The following is a description of a gene set: Mouse Gene Set: GOBP_MORPHOGENESIS_OF_AN_EPITHELIAL_SHEET The process in which the anatomical structures of an epithelial sheet are generated and organized. An epithelial sheet is a flat surface consisting of closely packed epithelial cells. studied in species Mus musculus, and this is the list of marker genes: Pdcd10, Sos1 (SOS Ras/Rac guanine nucleotide exchange factor 1), Pard3, Tmeff2, Clasp1, Pdpn, Flna, Lrp6, Lrg1, Hoxb2, Pals1, Rhoa, Cd151, Hbegf, Wnt7a, Fermt1, Ajuba, Hoxb4, Itgav, Jag1, Cd44, Megf8, Rhoc, Col5a1, Flrt3, Fermt2, Map3k1, Dvl1, Mrtfa, Mtor, Tbx20, Arhgap12, Dvl2, Bmp5, Mmp12, Arhgap35, Srf, Clasp2, Pten, Plet1, Carmil2, Snai2, Ccn1, Notch2, Msx2, Chuk, Phldb2, Phactr4, Scnn1b, Wnt5a, Ddr1, Itga5, Arhgap24, Zfp568, Itgb5, Bmp7, Rreb1, Tor1a, Lin7c, Notch1, Dll4, Scnn1g, Acvrl1, Dag1, Lama1, Sox11, Ceacam1, Vangl2